The following is a description of a gene set: Genes up-regulated in comparison of unstimulated macrophage cells versus macrophage cells stimulated with LPS (TLR4 agonist) for 20 min. from publication Litvak V, Ramsey SA, Rust AG, Zak DE, Kennedy KA, Lampano AE, Nykter M, Shmulevich I, Aderem A (PMID 19270711) The innate immune system is a two-edged sword; it is absolutely required for host defense against infection, but if left uncontrolled can trigger a plethora of inflammatory diseases. Here we used systems biology approaches to predict and validate a gene regulatory network involving a dynamic interplay between the transcription factors NF-κB, C/EBPδ, and ATF3 that controls inflammatory responses. We mathematically modeled transcriptional regulation of Il6 and Cebpd genes and experimentally validated the prediction that the combination of an initiator (NF-κB), an amplifier (C/EBPδ) and an attenuator (ATF3) forms a regulatory circuit that discriminates between transient and persistent Toll-like receptor 4-induced signals. Our results suggest a mechanism that enables the innate immune system to detect the duration of infection and to respond appropriately. studied in species Homo sapiens Human Gene Set: GSE14769_UNSTIM_VS_20MIN_LPS_BMDM_UP, and this is the list of marker genes: KIF12, CR1L, TMEM74B (transmembrane protein 74B), SLC22A13, CHDH, MAMSTR, CHST10, FDXR, ACOT13, SMCO3, SLC25A53, SERINC2, GRK4, ALPK3, SLC24A4, KLHL41, CSN2, OPTC, PARVA, SYP, GTF2H3, SYT11, IL13RA2, B3GAT2, USP30, SNUPN, ISLR2, TMEM260, ACTL10, GREB1L, VSIG1, ZDBF2, MAP7D2, MLANA, EFNB1, KRT32, SPC24, PCDHAC1, ESRRB, NRG4, PCED1B, SPATA21, CLMN, SGCE, MEGF11, TNFRSF9, FAM3A, SCRG1, NXNL2, SPATA13 (NCBI Gene Id 221178), CPXM2, TREH, BBS2, ITGA1, SIX6, IQCF1, ZDHHC23, TSPAN7, PADI4, KIF7, POU4F1, FAP, OR2S2, CASQ1, OR51B4, SLC16A2 (solute carrier family 16 member 2), C8G, GRB7, FGF9, BNIP5, CATSPER1, LRRC38, DANCR, SLC4A5, RPUSD4, SMOC2, CST7, SNHG11, MYL11, CLTRN, SCARNA13, FGB, CBY1, PITPNM2, EML6, CCR6, RWDD3, NHSL1, RASIP1, OPHN1, CORT, OPN4, WDR31, DCC, KLK11, PIGR (NCBI Gene Id 5284), SCNN1B, TRIM72, AHSG, NTN5, PCDH9, RNASE3, MMP14, OGFOD2, NAPRT, OVOL1 (NCBI Gene Id 5017), PLCB2, UBE2U, KLC3, AK5, KCNC3, IL18BP, TUT1, PDE10A, HAGH, ARMCX2, HES5, TMEM223, CLEC4F, CIMIP5, LCE1D, CHRM4 (NCBI Gene Id 1132), LEFTY2, EPN2, FKBP6, CEP95, VWC2, RFTN2 (raftlin family member 2), ADCY5, S1PR4, ATOH8, MPP3, SCEL, PDE9A, RAMP2, ERCC1, SBSN, EVC2, LRRN4, CLEC1B, CIITA, SLC1A6, ADCK1, C16orf89, RALYL, VSTM4, SHBG, NPY1R, KRT79, SLC25A2, BVES, IL36RN, IGLON5, CNKSR1, GABRE, ULK4, MAB21L4, GALR2, CNTN3, BNC1, DKK1, MYH1, CEP126, HOXB1, DAAM2, SPNS2, KLHL14, ADGRB3, SMTNL1, KRT1, AJM1, KIF9, ORM1, FMNL3, FITM2, ZIC5, LIPH, KRT222, OTULINL, CARTPT, SNHG10, CACNG6, KLK5, PKN3, MYOZ1, ATP4B, LINC01160, KCNG4, EPHA7, GNMT, HOATZ (NCBI Gene Id 399949), TSSK1B, CCDC167, LCN9, MIXL1, EHF, CCL24, KCNQ3, EPDR1